The following is a description of a gene set: studied in species Homo sapiens Human Gene Set: GOBP_INTERLEUKIN_10_PRODUCTION The appearance of interleukin-10 due to biosynthesis or secretion following a cellular stimulus, resulting in an increase in its intracellular or extracellular levels., and this is the list of marker genes: EPX, PYCARD, DLL1, CD83, F2RL1, VSIR, MIR194-1, CD46, CD28, BTK, TIGIT, FCGR2B, PDCD1LG2, CLEC7A, IL6, FOXP3, LILRA5, MIRLET7C (NCBI Gene Id 406885), FCER1G (Fc epsilon receptor Ig), TLR9, HLA-DRB1, IL21 (interleukin 21), IL20RB, TSLP, TREM2, PIBF1, TUSC2, TLR4, IL12B, IL23A, IL13, LILRB4, CD40LG, LILRB1 (NCBI Gene Id 23445), HMGB1, MIR145, CD47, IRF4, IL23R, AGER, TRIB2, HSPD1, TNFRSF21, MIR98, BCL3, JAK3, RBM47, LGALS9, HGF, XCL1, ISG15, IDO1, TYROBP, INAVA, THBS1, NOD2, PRKCZ, SYK, CD274, IL4 (interleukin 4), RAD21, PRG2, SASH3, PLCG2, STAT3, TNFSF4, MIR106A